Given this list of marker genes Gas6, Trp53, Enpp1, Igf1, Tnfrsf21, Akap12, Cers6, here is a description of the gene set: Mouse Gene Set: GOBP_OLIGODENDROCYTE_APOPTOTIC_PROCESS Any apoptotic process in an oligodendrocyte. Oligodendrocytes belong to a class of large neuroglial (macroglial) cells in the central nervous system, where they form the insulating myelin sheath of axons. studied in species Mus musculus